The following is a description of a gene set: Mouse Gene Set: GOBP_REGULATION_OF_THYMOCYTE_MIGRATION studied in species Mus musculus Any process that modulates the frequency, rate or extent of thymocyte migration., and this is the list of marker genes: Xcl1, Ccr7, Adam8, Aire, Ccr2